The following is a description of a gene set: The chemotaxis process that directs the migration of an axon growth cone of a dopaminergic neuron to a specific target site in response to a combination of attractive and repulsive cues. Human Gene Set: GOBP_DOPAMINERGIC_NEURON_AXON_GUIDANCE species: Homo sapiens, and this is the list of marker genes: VANGL2 (VANGL planar cell polarity protein 2), RYK, CELSR3, WNT5A, WNT7B, FZD3